Given this list of marker genes Slc6a4, Cnga1, Rap1a-ps2, Gm12187, Gm20118, Mdga2, 1700064H15Rik, Sox30, Akr1c12, Gm6871 (NCBI Gene Id 628359), Idh3g, Mir181a-2, Wbp4, Adam19, Smarca2, Gm25761, Cyp2j7, BB557941, Polg, Tmem47, Il15ra, Csmd1, Ptpn20, C920006O11Rik, B9d1, Gm10443, Snw1, Fmc1, Gm18957, Gm29507, Clcn3, Cd34, Mbnl3, Unc13b, Traf3, Lmln, Ilf2, Sfi1, Gm22126, Gm13331, Unc45bos, Fam219aos, 4933408A14Rik, Traj43, Gm24119, Wipf2 (WAS/WASL interacting protein family, member 2), Neat1, Mcmbp, Gm6059, 4930420N18Rik, Pik3r6, Tpst1, Gspt1, Panx3, Aldh1l2, Malat1, Urgcp, Ppfibp1, Sptbn1, Gm40190, Csnk2a2ip, E430014B02Rik, Tapt1, Cad, Frmd8os, Kcne3, St6galnac2, Gm25697, Nsmce1 (NCBI Gene Id 67711), here is a description of the gene set: Mouse Gene Set: RPA2_TARGET_GENES from publication Yevshin I, Sharipov R, Kolmykov S, Kondrakhin Y, Kolpakov F (PMID 30445619) Genes containing one or more binding sites for (Rpa2) in their promoter regions (TSS -1000,+100 bp) as identified by GTRD version 20.06 ChIP-seq harmonization. species: Mus musculus